The following is a description of a gene set: species: Mus musculus Mouse Gene Set: GOBP_TRANSITION_BETWEEN_FAST_AND_SLOW_FIBER The process of conversion of fast-contracting muscle fibers to a slower character. This may involve slowing of contractile rate, slow myosin gene induction, increase in oxidative metabolic properties, altered electrophysiology and altered innervation. This process also regulates skeletal muscle adapatation., and this is the list of marker genes: Myh7, Tnnc1, Tnni1, Nfatc1, Ppp3ca, Tead1, Gtf2ird2, Atp2a2, Tnnt1, Actn3